Given this list of marker genes OCA2, SLC45A2, TYR, TYRP1, DCT, here is a description of the gene set: Human Gene Set: REACTOME_MELANIN_BIOSYNTHESIS studied in species Homo sapiens Melanin biosynthesis